Given this list of marker genes PLCB4, WDR7, PSD2, EIF4E3, USP32, ADAMTSL1, CTXN3, BLTP3A, SCN2A, RAB9A, WNK1, ERO1B, ACSL4, ZNF451, PMEPA1, AP2B1, LRRTM3, ZBTB10, PAK3, CCBE1, GGACT, ZC3H14, PHC3, RIPOR2, RNF217, DCLK1, DELE1, MARK1, CYP26B1, NPY1R, ADAM23, IKZF3, MBTD1, CDK19, REV3L, MTMR9, ZBTB37, FZD3, ELOVL4, MYH2, ENC1, KMT2A, TEAD1 (TEA domain transcription factor 1), TUBB1, NLGN3, EXD2, ABCB5, NAMPT, ARMC10, LDB3, ABTB3, RFX1, CELF4, ZDHHC3, LSAMP (limbic system associated membrane protein), CDH12, ASPH, RFX3, NFASC, A1CF, SENP6, GOLGA6B, SIGLEC8, CREB1, DCTN4, FGF7 (NCBI Gene Id 82955), ZIC4, PPM1L, KCNJ5-AS1, SORT1, KLHL13, CBL, SGIP1, EIF4G3, NR3C2, MMP1, GRM3, GLRB, SLF2, FHOD3, ITFG1, GPR160, SIX4, PRKAB2, NRXN1, ZNF273, UBQLN2, KCP, ASB5, CNTNAP2, GABRA5 (gamma-aminobutyric acid type A receptor subunit alpha5), RANBP10, RWDD3, SCAI, CSMD3, SCN1A, PBLD, ABR, EIF4A1 (eukaryotic translation initiation factor 4A1), IGF1R (NCBI Gene Id 51049), ZNF10, WWC2, TSC22D1, SRSF10, SORBS1, ZBTB7A, GTF3C3, RAB3IP, RTN4RL1, UBN2, TDP1, MRTFA, GRIP2 (NCBI Gene Id 80852), MPC2, MAPK10, KMT2C, SNX20, HPCAL4 (hippocalcin like 4), BIVM, NAA30, ASCC2, RICTOR, BTBD7, C9orf153, SLC10A7, TMEM117, CREBRF, CPE, TGFBRAP1, SGCD, RBBP4, SPIN3, RIBC1, CSGALNACT2, APBA1, ELAVL3, PBOV1 (prostate and breast cancer overexpressed 1), AGA, GTF2H1, FAM20B, SOWAHC, LIPG (NCBI Gene Id 9388), RAB6D, FAM168B, MORC4, DUSP16, CAMTA1, ZNF500, PEX5L, ITGBL1, TIFA, EHMT1, ABCG2, TMEM70, AGAP5, GABRG1, BTC, ETS2, AGAP4, PLEKHM3, FBXW7, WDR44 (WD repeat domain 44), DYNLT5, CCDC186, TET3, ZBTB20, MAB21L2, MEX3C, MFSD8, OLAH, MID2, ZNF148 (zinc finger protein 148), VPS37A, GRIK2, GRID2, HSBP1, ANGPTL7, POGLUT3, MEIS2, PLCXD1, MBNL3, USP9Y, IGF2BP2, SPPL3 (NCBI Gene Id 25881), NFIA, VAPB, POU3F2, ADGRA1, GTF2A1, SESN3, LIMD1, PMP2, IFT80, DLGAP4, DEUP1, AGAP6, NCBP1, LRRC8C, ZFR, DNAJC18 (DnaJ heat shock protein family (Hsp40) member C18), ATAT1, EPCIP, LIAS, VXN, KLHL5, ANKS1B, ZNF146, CEBPG, KLHL29, SPECC1, ASXL3, KDM3B, CFAP161, FGD1, RNF139, AMER2, EPC1, LEP, ZSWIM6, PDCD6, ATRN, MARF1, AGAP11, RPL27A, TCFL5, VWC2, FAM149B1, ZC3H12C, ROR1, MID1, JADE1, PTBP3, IGF2, GRM4, CDCA7, LYRM7, TIPARP, TRAPPC6B, TMEM156, ZNF14, SPATA31D4, CCDC32, DYNLRB2, STMP1, TMEM252, CLASP1, PLEKHH2, ATP6AP1L, HMGA2, PER2, USP10, CPD, BAIAP2, SLC30A7, GNRHR, TTLL7 (NCBI Gene Id 79739), CARM1, HOXA5, GMCL1, NUS1, LHFPL2, TBX5, MAFA, NOTCH2, PLPPR1, CX3CR1, CLCC1, MB21D2, XKR6, METTL15, TRIM2, EIF3A, CENPN, MAGEE2, GINS3, ARRDC3, OSBPL8, SLC22A23 (solute carrier family 22 member 23), ST3GAL5, KAT6A, ADGRL2, COL4A3, BTNL3, RFX7, CCDC39 (coiled-coil domain 39 molecular ruler complex subunit), RXFP1, INSYN2A, TLL1, AGAP9 (ArfGAP with GTPase domain, ankyrin repeat and PH domain 9), ETV1, SETD9, GOLGA6A, ADAM12, TSPOAP1, PLXDC2, PRKAA2, TTC14, ETNK1, E2F5, ALOX12B, FMR1, SLC12A8, BROX, SLC2A12, DNMT3A, ALG6, TNRC6B, PDE11A, UNC5D, AIMP1, CARF, FLRT3, here is a description of the gene set: Human Gene Set: MIR5010_3P studied in species Homo sapiens Genes predicted to be targets of miRBase v22 microRNA hsa-miR-5010-3p in miRDB v6.0 with MirTarget v4 prediction scores > 80 (high confidence targets). from publication Chen Y, Wang X (PMID 31504780)